The following is a description of a gene set: species: Homo sapiens Round ear Human Gene Set: HP_ROUND_EAR, and this is the list of marker genes: PSMC3, TNNI2, CEP57, MYH3, TPM2, NALCN, TNNT3